The following is a description of a gene set: species: Homo sapiens Abnormal liver enzyme activity or concentration Concentration or activity of an enzyme is above or below the limits of normal in liver tissue. Human Gene Set: HP_ABNORMAL_LIVER_ENZYME_ACTIVITY_OR_CONCENTRATION, and this is the list of marker genes: PYGL, PHKB, NADK2, GLYCTK, PHKG2, NAGS, GRHPR, DPYS, ALDOB, PHKA2, UPB1, AGXT, SLC37A4, OTC